The following is a description of a gene set: species: Homo sapiens Genes predicted to be targets of miRBase v22 microRNA hsa-miR-323b-5p in miRDB v6.0 with MirTarget v4 prediction scores > 80 (high confidence targets). from publication Chen Y, Wang X (PMID 31504780) Human Gene Set: MIR323B_5P, and this is the list of marker genes: TMEM115, ZNF131, GGA2, IGLL5, SERF2, CABYR, PCTP, ALG2, PIK3R3, KRT33B, DMRT2, TOGARAM1, PTBP2, FMN2, MPC1, SETD5, CACNA2D1, RNF24, ARHGAP29, HSPD1, TAF5, BTAF1, MXD1, SAV1 (NCBI Gene Id 60485), SYT9, PTPN4, MEOX2, STK38, ALDOB, GORASP2, PRKCA, P3R3URF-PIK3R3, JAK1, IL1A, SETD7 (NCBI Gene Id 80854), ITGA6, RHOBTB1, CDKN2B, NLK, BOD1L2, ZMYM3